Given this list of marker genes TLX2, AMH, SMAD1, AMHR2, BMPR2, ACVR1, FKBP1A, SMAD9, BMP7, SMAD5, SMAD4, here is a description of the gene set: ALK2 signaling events Human Gene Set: PID_ALK2_PATHWAY studied in species Homo sapiens from publication Schaefer CF, Anthony K, Krupa S, Buchoff J, Day M, Hannay T, Buetow KH (PMID 18832364)